Given this list of marker genes Smad5, Pcna, Ercc1, Cmpk2, Nelfcd, Rfc2, Polr2e, Guk1, Npr2, Alyref, Polr3c, Pde4b (phosphodiesterase 4B, cAMP specific), Pold1, Polr2a, Rfc3, Ccno, Polr2g (polymerase (RNA) II (DNA directed) polypeptide G), Polr2j, Pole4, Gpx4 (NCBI Gene Id 625249), Rfc5, Ago4, Polr2k, Eloa, Polr1c, Rrm2b, Polr2f, Rae1, Ncbp2, Ssrp1, Rad51, Pnp, Polr1d (polymerase (RNA) I polypeptide D), Pold4, Nfx1 (NCBI Gene Id 93788), Ercc5, Clp1, Zfp707, Ercc8, Arl6ip1, Prim1 (DNA primase, p49 subunit), Polr1h, Ddb2, Gtf2f1, Tsg101 (NCBI Gene Id 22088), Taf9, Upf3b, Pom121, Polr2d, Taf1c, Polr3gl, Snapc4, Adcy6, Fen1, Gtf3c5, Nudt9, Taf6, Dguok, Taf13, Rala, Rbx1, Sdcbp, Sac3d1, Tk2, Ercc2, Gtf2h1, Surf1, Srsf6, Dut, Poll, Polb (polymerase (DNA directed), beta), Nudt21, Mpc2, Rnmt, Ak1, Tarbp2, Lig1, Polr2i, Vps37d, Trp53, Aaas, Tyms, Vps28, Vps37b, Sec61a1, Nme1, Nelfb, Xpc, Cda, Ell, Nelfe, Gsdme, Zwint, Dctn4, Edf1, Mrpl40, Hcls1, Bcap31, Cant1, Stx3, Sf3a3, Supt4a, Nt5c, Umps, Dad1, Cetn2, Rev3l, Supt5, Cstf3, Polh, Ercc4, Taf12, Adrm1, Rpa3, Nme4, Rfc4, Brf2, Nme3, Itpa, Ddb1, Taf10, Ercc3, Bcam, Gtf2b, Nt5c3, Pde6g, Gtf2h5, Gtf2h3, Snapc5, Pola2, Cox17, Impdh2, Rpa2, Hprt1, Pold3, Eif1b, Gmpr2, Mpg, Polr2h, Dgcr8, Rad52, Gtf2a2, Polr2c, Ada (NCBI Gene Id 11486), Aprt, Ak3, Usp11, Pola1, here is a description of the gene set: from publication Howe DG, Blake JA, Bradford YM, Bult CJ, Calvi BR, Engel SR, Kadin JA, Kaufman TC, Kishore R, Laulederkind SJF, Lewis SE, Moxon SAT, Richardson JE, Smith C (PMID 30224793) Mouse genes annotated to HALLMARK_DNA_REPAIR based on orthology mappings provided by the Alliance Genome Consortium Mouse Gene Set: HALLMARK_DNA_REPAIR species: Mus musculus